Given this list of marker genes Igtp, Irgm2, Agtpbp1, Lcmt1, Atg16l1, Wipi2, Agbl5 (ATP/GTP binding protein-like 5), Atg5, Icmt, Irgm1, Agbl4, Agbl1, Lcmt2, here is a description of the gene set: studied in species Mus musculus Mouse Gene Set: GOBP_C_TERMINAL_PROTEIN_AMINO_ACID_MODIFICATION The alteration of the C-terminal amino acid residue in a protein.